Given this list of marker genes VOPP1, AOPEP, ALPK1, UBQLN4, HCFC2, TAFAZZIN, UGGT1, QSER1 (NCBI Gene Id 79832), SLC12A7, SLAMF1, KLC2, KRI1, WRAP73, CCR9, ABCC10, CD8B, SLC26A6, TAOK1, CD8A, AKAP10, XYLT2, ZNF160, MAU2, ALDH8A1 (NCBI Gene Id 64577), MTG1, POLG2, KANK2, RGCC, CYB5R1, TTLL3, NFATC2IP, PTPRC, AP5Z1, H4C1, CHRNA3, VIPR2 (vasoactive intestinal peptide receptor 2), KDM4C, IL32, AQP3, GMEB2, TRIB3, SLA, TRBV10-2, RGL2, PLEKHA5, GDI1, SPSB3, PCSK5, AEN, E4F1 (NCBI Gene Id 1877), RHOT2, NSMF, PHF1, EPHX2, NSUN5P2, DGKA, PIK3IP1, CAPN10, MR1, CEP85, MPPE1, PLAG1, NCOA1, EPHB6, FHIP2B, RORC, SIT1, DBT, PGF, CD1C, PTPN4, FAM53C, PARD3 (NCBI Gene Id 56288), OGG1, DIPK1A, ZNF14 (zinc finger protein 14), DCUN1D2, BCL6, STAG3, STK32B, NEIL1, GTSE1, GSDMB, DBF4B (NCBI Gene Id 80174), CHMP7, AEBP1, IQCC, CAMK1D, LMF1, PLA2G15, RAB2A, NUDT13, CCDC103, EVI2A, INTS1, HAGH, POR, PTPN7, SLC27A3, MSL3, HDAC7, SKIC2, IPP, TOM1, CD4, ZNF335 (zinc finger protein 335), GLA, CLCN7, RESF1, HIVEP2, ELOVL4, B4GALT1, POM121, ZNF611, FBLN2, KLHDC4, PLXDC1, DUSP9, CD52, TMC6, PPP6R2, FASTKD5, DCLRE1C, PDE4C, PRR11, CEP131, SIRT7, RNF19A, TRAC, ABCA7, ISG20, PTGDR2, MICAL1, CREBBP, POGLUT1, KDM2A, S100A10, TCF7, CNPY4, BMAL1, CUL2, RBM38, CYP46A1, DAPK3, SPATA2L, FBXW12, ZNF839, ARHGEF1, RABL6, SATB1, ANKZF1, CCZ1B, CD247, ZNF587, ENTPD6, KLHL24, SPOCK2, OSBPL2, STIMATE, SLC35E1, ATP8B1, REEP4, IRAG2, AMDHD2, TM7SF2, ECE1, SKAP1, DUSP8 (dual specificity phosphatase 8), RXRB, EZH1, H2AC15, CHI3L2, GTF2H3, TCF20, HSD17B7, BRD9, CSNK1G1, KIF3B, ARHGAP45, PTPRK, ITPR3, SPAG9, THAP3, H4C11, EXT1, TRBC1, CARMIL1, SRF (serum response factor), QRICH1, HAUS2, IL23A, SETD1B, AKAP8L, SMPD3, FAT1, ABCG4, ZNF721, MAP2K7, STAG3L1, here is a description of the gene set: C57Bl/6 wild-type and STAT6 KO mice were used to study PPARg and IL-4 signaling. Bone marrow of 3 mice per group was isolated and differentiated to macrophages with M-CSF (20 ng/ml). 20 ng/ml IL-4 was used to induce alternative macrophage activation and 1 uM Rosiglitazone (RSG) was used to activate PPARg. From each mouse 4 samples were generated: 1. M-CSF, 2. M-CSF+RSG, 3. IL-4 and 4. IL-4+RSG. All compounds were added throughout the whole differentiation process, and frech media was added every other day. Control cells were treated with vehicle (DMSO:ethanol). After 10 days, RNA was isolated and gene expression profiles were analyzed using Mouse Genome 430 2.0 microarrays from Affymetrix. species: Homo sapiens Human Gene Set: GSE25088_WT_VS_STAT6_KO_MACROPHAGE_IL4_STIM_UP from publication Szanto A, Balint BL, Nagy ZS, Barta E, Dezso B, Pap A, Szeles L, Poliska S, Oros M, Evans RM, Barak Y, Schwabe J, Nagy L (PMID 21093321) Genes up-regulated in bone marrow-derived macrophages treated with IL4: wildtype versus STAT6 knockout.